The following is a description of a gene set: Interacting selectively and non-covalently and stoichiometrically with kinesin, a member of a superfamily of microtubule-based motor proteins that perform force-generating tasks such as organelle transport and chromosome segregation. studied in species Homo sapiens Human Gene Set: GOMF_KINESIN_BINDING, and this is the list of marker genes: ATCAY, STAU2, SPAG9, KIF18B, PRC1, KLC2, MAP7D2, SNCA, NEK6, AP1AR, DISC1, CROCC, MAPK8IP3, KCNC1 (potassium voltage-gated channel subfamily C member 1), TTBK2, LRP8, TOR1B, ACTB, MAPK8IP2, NEFH, FAM83D, KIF5A, TRAK2, CLSTN1, TOR1A, PLEKHM2, DCDC2, KCNA2, SHTN1, KIFAP3, CIMAP3, KTN1, ARHGEF10, KLC3, AP1G1, KLC4, DCP1A, SPTBN5, KIFBP, KIF1B, KLC1, IFT88, MAPK8IP1, RAB29